Given this list of marker genes Ttll13, Ttll7, Ttll1, Ttll11, Ttll9, Ttll6, Ttll5, here is a description of the gene set: Mouse Gene Set: GOMF_PROTEIN_GLUTAMIC_ACID_LIGASE_ACTIVITY_ELONGATING studied in species Mus musculus Catalytic reaction:(L-glutamyl)n-L-gamma-glutamyl-L-glutamyl- + ATP + L-glutamate = (L-glutamyl)n+1-L-gamma-glutamyl-L-glutamyl- + ADP + H+ + phosphate.